The following is a description of a gene set: from publication Chaussabel D, Semnani RT, McDowell MA, Sacks D, Sher A, Nutman TB (PMID 12663451) Monocyte-derived dendritic cells (DC) and macrophages (MΦ) generated in vitro from the same individual blood donors were exposed to five different pathogens, and gene expression profiles were assessed by microarray analysis. Responses to Mycobacterium tuberculosis and to phylogenetically distinct protozoan (Leishmania major, L. donovani, Toxoplasma gondii) and helminth (Brugia malayi) parasites were examined, each of which produces chronic infections in humans yet vary considerably in the nature of the immune responses they trigger. Human Gene Set: GSE360_T_GONDII_VS_B_MALAYI_HIGH_DOSE_DC_UP Genes up-regulated in comparison of dendritic cells (DC) exposed to T. gondii versus DCs exposed to 50 worms/well B. malayi. species: Homo sapiens, and this is the list of marker genes: NKTR, CPNE1, IL5, GBP1, ZHX2, ENO2, SNX29, TRAF1, RFTN1, PHACTR1, KRTAP26-1, KMT2A, PSME2, TXN, SERPING1, PMP22, DNAJB6, ZSCAN9, LAMP3, NRP2, PRPF3, ASIP, SYCP1 (synaptonemal complex protein 1), VRK2, SLC1A2, COL9A2, PAX2, IFITM3, GADD45B, RAPGEF4, TUBB4A, GYS1 (NCBI Gene Id 2997), CCN1, PTPRT, BNIP3, PLCL1, TAP1, BAAT, MAGI2, KRT16, TRADD, BTG1, GP1BA, MYRF, TIE1, DUSP5, NCR2, CHST2, CAMK2A, BTG3, GFI1, RELB (RELB proto-oncogene, NF-kB subunit), TAGLN2, CCL17, OR2B6, TRAF5, IFIT3, APC, CFLAR, NFKB1, HTRA2, POU6F1, IMPA1, ASIC2, NDUFA7, CD83, STX11 (syntaxin 11), N4BP2L1, CD200, IGFBP7, STAT4, AFF2, WT1-AS, TRIM31, PNRC1, WTAP (WT1 associated protein), ITSN1, CAD, FERMT2 (FERM domain containing kindlin 2), DGKB, CETN1, SIKE1, DVL1, FGF18, DYNLT1, MAGEA10, LRRC23, SSTR5, TUSC3, CNGA1, ARID1A, TOP2A, ALOX15B, PAWR, LTBP2, NFKBIA, IGFBP3, ID4, PDZK1, COL9A3, B4GALNT1, CYRIA, MGLL, E2F1, ACKR3, RAPGEF2, COL6A3 (collagen type VI alpha 3 chain), PIK3R3, RHCE, PPEF1, GUCY1B1, IDUA, MT1A, SFTPC, SAT1, H6PD, NFKB2, TSC22D3, EIF3J, IL15RA, COL4A5, MS4A3, TRIM9, RALGAPB, DIPK1A, CXCL9, PLK2, CDH6, MRPL28, RSAD2, ANP32E, SGCB, CDK9, SLC12A2, GCDH, HGF, CXCR4, POLA2, IL7R (NCBI Gene Id 3575), FASLG, DIXDC1, REL, ZNF75D, NPHS1, BASP1, GCH1, BCL2A1, DUSP1, NPAS2, SOD2 (NCBI Gene Id 79099), KDM2A, MATN1, CCR7, ACTG2, REEP2 (NCBI Gene Id 51308), CBARP, TNFAIP3, SNAP25, SYN1, MYL6, DNASE1L3, CEP170B, CAV3, LY75, IL1A, IGKC, ENO1, FAM131B, GLDC, ORC2, CECR7, AK4, SYT1, RGS1, ISG20, ERAL1 (Era like 12S mitochondrial rRNA chaperone 1), CADM1, IFI35, ADAM11, ATF5, TNFAIP2, TPI1, CYB5A, PSMA6, CAMK2B, STT3A, DUSP4, ABTB2, TIAM1, EEIG1, SOCS3, KLF7, EIF2AK1, PGAP4, CDH15, NR4A3, SSUH2, IL15